The following is a description of a gene set: Mouse Gene Set: GOBP_RESPONSE_TO_SODIUM_PHOSPHATE studied in species Mus musculus Any process that results in a change in state or activity of a cell or an organism (in terms of movement, secretion, enzyme production, gene expression, etc.) as a result of a sodium phosphate stimulus., and this is the list of marker genes: Alpl, Ank, Fgfr3, Abcc6, Enpp1, Phex, Runx2, Slc34a1, Fgfr1, Grp, Fgf23, Ednrb, Hnrnpd